The following is a description of a gene set: species: Mus musculus This event has been computationally inferred from an event that has been demonstrated in another species.<p>The inference is based on the homology mapping from PANTHER. Briefly, reactions for which all involved PhysicalEntities (in input, output and catalyst) have a mapped orthologue/paralogue (for complexes at least 75% of components must have a mapping) are inferred to the other species. electronically inferred by orthology from the curated human pathway Reactome Pathway: L1CAM interactions part of: Axon guidance, and this is the list of marker genes: Ap2s1, Egfr, Fgfr1, Lypla2, Tubb4b, Tubb4a, Mapk3, Tuba1c, Dpysl2, Numb, Ap2m1, Tuba1a, Tuba3b, Dnm2, Sptbn4, Nfasc, Sptbn2, Itga5, Rdx, Tuba1b, Tuba8 (tubulin, alpha 8), Sdcbp, Ank1, Gap43, Tuba4a (NCBI Gene Id 22145), Map2k1, Csnk2b, Ap2b1, Ranbp9, Ncam1, Tubb2b, Ap2a1, Tubal3, Tubb6, Itga2b, Map2k2